The following is a description of a gene set: studied in species Homo sapiens Binding to polymeric ADP-D-ribose, a polymer that is composed of poly-ADP-D-ribose units linked through 1,2-glycosidic bonds at the ribose ring. Human Gene Set: GOMF_POLY_ADP_D_RIBOSE_BINDING, and this is the list of marker genes: PARP2, RNF146, XRCC1, APLF, HPF1, MARCHF6-DT (NCBI Gene Id 101929977), AIFM1